The following is a description of a gene set: species: Homo sapiens The chemical reactions and pathways involving a flavin, any derivative of the dimethylisoalloxazine (7,8-dimethylbenzopteridine-2,4(3H,10H)-dione) skeleton, with a substituent on the 10 position. Human Gene Set: GOBP_FLAVIN_CONTAINING_COMPOUND_METABOLIC_PROCESS, and this is the list of marker genes: FLAD1, SLC52A2, SLC52A3, VCP (valosin containing protein), SLC52A1, RFK